Given this list of marker genes EGLN3, LMO2, CEBPB, TRAFD1, ATP10D (ATPase phospholipid transporting 10D (putative)), INO80D, PRUNE2, CCL2, ECI2, CXCL11, PLEKHA4, IRF1, CDC42EP4, MYOZ1, PHLDA3, SLC35C1, IGFBP3, DRAM1, AK4, DNAJC12, PTAFR, THRB, SAG, LAP3, HLA-E, CASP7, CADPS (calcium dependent secretion activator), CFHR2, TAP1, IFI30, HAL, PGLYRP4, SOCS1, CTSS, IL15, SLC25A22, GTF2B, CD40, IL12A, GNAZ, OAS2, CCNL1, SLIT3, LIG4, SLC25A28, KDM6A, MCUB, SLC12A7, PRDM5, GSTK1, CEACAM1, CAND2, CCDC68, TCTA, ZNF410 (NCBI Gene Id 57862), TOP1, TMEM140, FASTK, OPTN, PADI3, GUK1, DGKQ, RAB27A (NCBI Gene Id 5873), ARTN, INSIG1, SCMH1, TENM4, UBE2L6, KCTD14, CD47, SPSB1, CISH, CBX2, FOXN3-AS2, IL10RB, TRPM3, ATP10A, RRH, WARS1, CXCL9, C1orf54, ICOSLG, NREP, USP15, PRAMEF11, RNPEPL1, RNF114, PRM2, BAALC, LIFR, SIN3B, PILRA, TLX1, ATP6V1B2, SERPINA5, ISG20, CEP192, KPLCE, ARID5B, APOL1, BATF3 (NCBI Gene Id 55509), GBP1, LGALS8, CD40LG, APOL2, MORC3, TRAPPC2, GCNT3, CXCL2, CLEC2B, FBXW4P1, CRYBG1, PLSCR1, PCLO, RPS6KA2, IL15RA, CACNG5, TACR3, IL7, WNT6, ATF3, TXNL4B, DDX23, DIO1, TRIM22, PSMB10, GBP2, CCT8L2, ACTL6B, PAPPA2, IDO1, EWSR1, APOL6, MSRB1, FAS, GCH1, MMP10, IFI35, CFAP44, MECOM (MDS1 and EVI1 complex locus), TTF2, MBIP, CREM, STK3, PSMB9, CBR3, CXCL10, MYH14, ZNF613, RNF19B, MSX1, CBLC, TBR1, IRF8, PAPOLB, CLDN10, EEF1AKMT3, EGR2, CTSL, JAK2, PREX2, DYNLT1, STAG1, PPA1, CFH, PEG3, S1PR2, RPS6KA5, FOXI1, ASRGL1, TNIK, CAPN11, MAFF, ICAM1, HLA-F-AS1, PSMB8, FMOD, ITK, BRAF, CDIPT (CDP-diacylglycerol--inositol 3-phosphatidyltransferase, NCBI Gene Id 10423), RRAGC, ITPKC, STOML1, APOL3, DOCK4, MADCAM1, NR1I3, TRIM3 (tripartite motif containing 3), HRH2, GAS1, IGFLR1, ETV7, NOC2L, HEG1, CFB, DPYD, SEMA3F, FERRY3 (FERRY endosomal RAB5 effector complex subunit 3), HK1, CXCL5, here is a description of the gene set: Human Gene Set: GSE42021_CD24HI_VS_CD24INT_TCONV_THYMUS_DN species: Homo sapiens Genes down-regulated in thymic T conv: CD24 high versus CD24 int. from publication Toker A, Engelbert D, Garg G, Polansky JK, Floess S, Miyao T, Baron U, Düber S, Geffers R, Giehr P, Schallenberg S, Kretschmer K, Olek S, Walter J, Weiss S, Hori S, Hamann A, Huehn J (PMID 23420886) We investigated at which stage of maturation commitment to a stable Foxp3-expressing phenotype takes place. We assessed stability of Foxp3 expression in thymic Foxp3+ Treg subsets of different maturity, defined by CD24 expression. Next we compared gene expression profiles of Foxp3+ Treg subsets (+) of different maturity (24lo, 24int, 24hi) and could identify a set of genes that were specifically up or downregulated in Foxp3+ Tregs, but not in Foxp3- conventional T cells, in a maturation-dependent manner.